Given this list of marker genes LMAN2, CYBA, MYO18A, GATA2, SFTPD, FCER1G, F2RL1, ITGA2, SIRPA, COLEC10, SIRPG, CLEC7A, FCN3, CD300LF, PRKACA, RAB27A, FCGR1BP, C4B, SPACA3, RAP1GAP, PTPRJ, LYAR, GAS6, IL2RG, APOA1, FCN2, BCR, CD36, COLEC11, NCKAP1L, FCN1, ANO6, ABCA7, FCGR2A, STAP1, SIRPB1, FCGR1A, RAP1A, IL2RB, C4A, PTPRC, PTX3, RAB31, STAT3, MBL2, TREM2, CCL2, FPR2, AHSG, CAMK1D, IL15RA, IFNG, CD47, AZU1, C3, PLA2G5, MIR20A, TUB, C2, PLCG2, DOCK2, BTK, ARAP1, CFP, MIR183, APPL2, IL15, SLC11A1, PYCARD, MERTK, APOA2, FCGR2C, SOD1, CALR, MIR17, TULP1, FCGR2B, here is a description of the gene set: studied in species Homo sapiens Any process that activates or increases the frequency, rate or extent of phagocytosis. Human Gene Set: GOBP_POSITIVE_REGULATION_OF_PHAGOCYTOSIS